The following is a description of a gene set: studied in species Homo sapiens Human Gene Set: GOBP_ANTIMICROBIAL_PEPTIDE_PRODUCTION The synthesis or release of an antimicrobial peptide during an immune response, resulting in an increase in intracellular or extracellular levels. Such peptides may have protective properties against bacteria, fungi, viruses, or protozoa., and this is the list of marker genes: MMP7, KLK3, KLK7, ELANE, LGALS4, IL17F, EVPL, PGC, IL17A, SPINK5, KLK5